Given this list of marker genes Inppl1, Snca, Ndrg4, Ptprj, Apod, Ptgir, Adipoq, Nherf1, Ptpn2, Hgs, Myocd, Phf14, Lrp1, here is a description of the gene set: Mouse Gene Set: GOBP_NEGATIVE_REGULATION_OF_PLATELET_DERIVED_GROWTH_FACTOR_RECEPTOR_SIGNALING_PATHWAY Any process that stops, prevents, or reduces the frequency, rate or extent of the platelet-derived growth factor receptor signaling pathway. studied in species Mus musculus